The following is a description of a gene set: Neighborhood of FSHR follicle stimulating hormone receptor in the MORF expression compendium Neighborhood of FSHR studied in species Homo sapiens Human Gene Set: MORF_FSHR, and this is the list of marker genes: RBBP7, NEB, PSG1, ZBTB14, ABCB10, ADAM22 (ADAM metallopeptidase domain 22), R3HCC1L, ATP8B1, SULT4A1, GPLD1, PHF10 (NCBI Gene Id 55274), DMPK, COL8A1, IFNA10, ST8SIA1, TBXT, PHOX2B, TENM4, ZSCAN26, TRIM24 (NCBI Gene Id 8805), CCR3, SLC17A1, CRHR1, ZNF266, P2RY10, TSPAN2, MC5R, PDE10A, PRKCA, NR1I2, DMD, NPFF, DBT, EPHB2, TTN, RYR3, POLR1HASP, ADGRL2, BMP10, POLR3F, AQP7, IL7, MSH3, SLC6A2, MON2, FSHR, FGF2, GHRHR, FLRT2, WBP4, ABCB1, COL19A1, CMKLR2, SUPT3H, NHEJ1, MAP2, FAM13A, COQ7, SIM2, GJB5, POU6F2, GPR171 (G protein-coupled receptor 171), CTSB, IL16, HNF1A, NOS2, RUNX2, KCNA5, IFNA2, MLLT10, HSD3B2, CYP2C19, PLA2R1, CADM4, SLC26A4, THPO, TANC2, NR3C2, F2RL3, COLGALT2, DRC3, EYA1, LDB3, TMEM26, IL5, ADAM20, ABO, IL4, CYP4F2, PDE4D, GCM1, KCNJ6, CPB2, SPA17, CPEB3, AMOT, TSSK2, GYPA, TNK1, GABRB2, HEPH, NOL4, PVR, SYT5, BRWD1, LGI1, ATP2B2, F2RL1, MYH2, HTR1E, DGCR5, FZD5, ULK2, KDR, ITIH3, NXPE3, HCRTR2 (NCBI Gene Id 3062), MAP3K1, ATF2, KNG1, CAMK4, CHRNB4, POU6F1, TSHB (NCBI Gene Id 7252), SERPINA4, FGF9, PTPRR, RB1CC1, BRINP3, CDR1, LECT2, PTPN20, TPD52L1, AOC4P, CFH, ELAVL2, STAC, RORB, IFNA8, IFNA1, SGPL1, KLRC4, EXOC4, PDE6A, CDC42BPA, NFAT5, GUCY2C, GPR18, ZNF141, ISL1, SGCD, FGF18, PAXIP1, PART1, GPR19, TRIO, CAMTA1, RAD51D, IL11RA, SIX6, NDP, CCL16, SIRPB1, PLPPR4, TBX19, FBXL4, RYR1, DRD1, COX6A2, CDH4, USP46, FNTB, PAX6, GRIK1, KRT2, AMMECR1, MYT1, CEP162, DAZL, SLC46A3, OR2B6, PTPRB, CACNA2D1, PPP1R12B, RXRG, ERC2-IT1, SLC15A1, VSTM4, RREB1, PGM3, GNG4, SLC33A1, GUCY2F, PCM1, BRD4 (NCBI Gene Id 90616), FAS, KRT34, IGKV7-3, TFDP2, FUT1, RNF24, OCM (NCBI Gene Id 91268), MAGEA8, MDM2, C1orf216, LILRA1, ENTPD3, ZNF33B, ZNF157, CCR6, ATP4B, ECM2, SLC22A6, TACC2, RPS6KA5, OPLAH, GCA, SLC4A8, IFNW1, S100A5, PCDHB17P, ATP10B, MPP3, JADE3, SMYD3, PRIM2, PHLDB1, EXOC6B, ABCC8, CXCL5, BCL2L11, SRPK3, TLL1, ATXN3, COL14A1, RGS7, ARL3, H3C6, EDIL3 (EGF like repeats and discoidin domains 3), IPO9, CLCN3, ATF6B, SPRR2C, TTTY1, IFNA14, NTNG2, SLC17A3, ZNF202, FOSL1, ZNF132, YLPM1, JRKL, CALN1, ADAMTSL3, PDCD1, CYP2E1, C6, OR10H3, DDX52, MINDY2 (NCBI Gene Id 54629), RBMS3, HSPA1L, ITGBL1, ZBTB40, MAGEA9, PPM1E, CDC73, MAP2K7, GLRA3, LORICRIN, APOBEC1, ERCC4, DNAJC22, FRY, PCDHGB7, RSC1A1, CKM, B4GALT6, CD8A